The following is a description of a gene set: studied in species Homo sapiens Human Gene Set: GOBP_METANEPHROS_MORPHOGENESIS The process in which the anatomical structures of the metanephros are generated and organized., and this is the list of marker genes: KIF26B, SMO (NCBI Gene Id 6608), PKD2, HES1, BMP4, LIF, FRAS1, PAX2, STAT1, WNT7B, SOX8, SIX2, SALL1, AGTR2, CTNNB1, WNT9B, PKD1, GDNF, FOXJ1, BASP1, WT1 (WT1 transcription factor), WNT4, LGR4, HES5, SOX9, PAX8 (paired box 8), CALB1, FGF10, GREM1, LHX1